Given this list of marker genes COL11A1, MATN3, BGN, DDR2, INPPL1, here is a description of the gene set: studied in species Homo sapiens Wide, concave posterior rib end. Posterior rib cupping Human Gene Set: HP_POSTERIOR_RIB_CUPPING